Given this list of marker genes C1QTNF9, DPP4, BMP7, HSPD1, CGB3 (NCBI Gene Id 1082), VGF, NLRC4, GTF2H4, TNF, INHA, AKT2, IL22, NCF1C, AMBN, CCDC88A (coiled-coil domain containing 88A), RHEB, GFRAL, ERCC6, IFNA8, CXCL11, AGAP2, WRNIP1, SEMA4G, NRG3, SPRY2, RASAL1, PPP2R5B, SRC, TBC1D25, FGF8, MAP2K1, ARHGAP20 (Rho GTPase activating protein 20), APOA2, IL27, TBC1D13, TBC1D20, APLN, DDOST, VEGFA (vascular endothelial growth factor A), TNFSF9, CRH, LRRC32, MLST8, WNT8A, PGF, ARHGAP12, DNAJC2, RALBP1 (ralA binding protein 1), IL3, PLEKHG6, CXCL10, CCN6, THNSL2, PPBP, GHRH, EEF1A1, MMP16, LAMA5, PPP4R3A, FBLN1, INSR, EPO, SLC39A10, DEFB130A, STC2, NBL1, CTSA, AXIN1, RGS1, AZIN1, TNFSF14, ECRG4 (NCBI Gene Id 84417), DNAJA2, NPRL3, BCAS3, OGN, DMWD, TBC1D3L, PDGFRB (NCBI Gene Id 5159), LRRC52, TBC1D16, PARP1, SYDE1, CLCF1, TNFSF4, GHRL, ARHGAP24, DOCK5, SLC27A1, SIPA1L1, AGAP3, FBN2, SKP1, SUMO1, CKS2, SUZ12, ARAP3, ARHGEF19, GARNL3, CCN3, DNAJB2, FURIN, SPDYA (speedy/RINGO cell cycle regulator family member A), LTA, GNAS, KL, PDYN, GUCA1A, HRAS, LLGL2, APH1B, CXCL9, RAF1, IFNL3, TYMP, IFNG (NCBI Gene Id 3458), DAD1, MOB1A, IZUMO1, AKT1, DLL4, RANBP1, MID1IP1, ARF4, CD86, PPY, NRG1 (neuregulin 1), ARHGAP11A, NBN, GPR15LG, ARHGAP45, SGSM1, MBTPS2, SEMA6D, MT3, SH3PXD2A (NCBI Gene Id 9644), SEMA4D, PARP6, RGPD4, FGF17, DNAJB4, PAK2, APOE, CXCL5, TP53, LRPAP1, LACRT, ATP1B1, ARHGAP25, PREX1, CSF1, ARHGAP10, ADCYAP1, TNKS1BP1, CHML, GAST, CDKN1B, CCL8, CSHL1, ABI1, WNT2B, CCL5, RGS14, RGCC, GRM5, TNFSF15, CRIPTO (NCBI Gene Id 6997), DEFB110 (defensin beta 110), CCL7, TBC1D2, COPA, LGALS1, GDF6, EBAG9, SGSM3, RABGAP1, FGF5, PPP1R15A, NF1, RGS10, DBF4B, WNT16, DNAJC7, IL6 (NCBI Gene Id 3569), ANG, IL19, RACGAP1, GCN1, WNT3A, FAM3C, PRKACA, STRADA, SLX4, POMC, TBC1D2B, BCR, ATP2A3, TBCK, PARP16, UBE2N, DCP1A, PCNA, MARK2, TNFSF10, FSHB, ARHGEF12, AHSA1, ATG13, CFLAR, ASAP3, METRNL, INSL3, TNFSF18, IL1B, PYCARD, PPP2R5C, STK4, NPVF, EVI5L, AGFG1, IL32, EDA, ARHGEF1, PREX2, DAND5, NTF4, IFNA16, IL17F, PVR, ARHGAP22, TBC1D9, GAL, EIF5, NLRP3, PDZK1, NCF2, INHBB, RGS17, RBCK1, IL36RN, ARHGAP18, RABEP2, IL36A, STC1, CRIPTO3, GNAQ, ARFGAP1, HSPB2 (heat shock protein family B (small) member 2), DEFB130B, SYNGAP1, NCF1B, JAG2, WNT7B, ACTN2, MOB1B, APAF1 (apoptotic peptidase activating factor 1), MAP3K20, PDGFC, ARHGAP5, ARHGAP30, PENK, DEFB103B, ACAP2, RALGAPB, NAA15, ICOSLG, ARRB1, PLCB3, DELE1, GPRC5B, SVBP, NENF, SIPA1L3, TAOK1, COX17, BTC, PSMD14, NRTN, FNDC5, SEMA3D, RGPD3 (RANBP2 like and GRIP domain containing 3), TOR1AIP2, NAA25, PTK2B, CLU, NPPA, ANGPT2, BAG6, SEMA3C, MOB2, ARHGEF10L, OXT, DNAJA1, HSCB, IFNA6, PEX12, ADIPOQ, APOC1, IFNL2 (interferon lambda 2), TBC1D24, SRGAP2, PDGFB, CASP9, FGF3, TREM2, EDN1, GNB5, CGA, SMAP2, GALP, RGPD8, PARK7, ULBP2 (UL16 binding protein 2), RINL, NDUFA13, CA9, BNIP2, GHR (growth hormone receptor), ANK2, NDP, CD24, ARHGAP27, WNT8B, STXBP5L, TBC1D26, CCL3, ARHGAP39, FZR1, C7orf50, ASAP1, DCP1B, NKX3-1, IL5, HDGF, CRLF1, CXCL12, GNA12, NCF1, CCL18, PMCHL2, TBC1D3, ARHGEF16, CSH2, CXCL3 (NCBI Gene Id 2921), AJUBA, IL10, TNFRSF11B, CTF1 (NCBI Gene Id 1489), CLPSL2, NOXO1, INHBA, CAV1, RIN3, RASA1, TAB1, DNAJC10, PGLYRP1, ARHGAP8, PTHLH (parathyroid hormone like hormone), ADM, REG1A (NCBI Gene Id 5967), STXBP5, SEMA3B, TGFB1 (transforming growth factor beta 1, NCBI Gene Id 7040), BMP10, CMTM7, ERCC5, EED, CDK5R1, DEFB104A, IL17A, SGSM2, ARHGAP40, DOCK7, NLRP1, STAP1, ARHGAP35, DNAJC15, SEC23A, WNT10B, RLN2, WNT5A, TRH (thyrotropin releasing hormone), THBS4, AVP, ADAP1, SEMA6B, HMGA1, C5, RPLP1, UBE2L3, FGF2, PIN1, FGF20, FGF21, TG, PRKCD, NOD1, PLEK, TAOK2, JAK2, TBC1D3F, ARHGDIB, ENG, TBC1D10B (TBC1 domain family member 10B), TMEFF1 (NCBI Gene Id 8577), BCL2L13, WNT3, ARHGAP1, ARAP1 (ArfGAP with RhoGAP domain, ankyrin repeat and PH domain 1), FGF16, APELA, CCL24 (NCBI Gene Id 6369), TOM1L1, PITRM1, WNT7A, INHBE, ADAP2, TBC1D5, FGF19, PCOLCE2, LTF, MOB3B, C3, FGF13, FAM3B, ARHGEF15, RABEP1 (rabaptin, RAB GTPase binding effector protein 1), CCND1, ADA2, HSP90AB1, NXNL1, DBNL (drebrin like), ARHGAP26, NCF4, CAB39L (NCBI Gene Id 81617), RETNLB, TIPRL, TBC1D8, IL1RN, IL24, CTSG, LCK, ARHGAP19, PF4V1, GUCA1B, DEPDC1, PHACTR4, RASAL3, LRRC55, CAPRIN1, NEK9, CDK5R2, HFE, CX3CL1, CD80, ARHGEF11, NODAL, NPY, THY1, TSHB, ARHGAP33, IL23A, BMP8A, ERFE, RING1, IGF2, IAPP, CMTM5, RIN1, ARHGDIG, IL37, PPP2R5D, PRL, PMCH, HACD3, PLXNB1, FAM3D, GMFG, CCL2, LTK, RGS12, IFNK, CCL20, NAA16, MYBPC3, FRS2, RASA2, DDIT3, RAP1GAP, RPTOR, VEGFD, TBC1D3K, SERINC2, NCOR2, MAP3K13, LEFTY1, PSME1, CCL4L2, ATP1B2, IL26, PPP2R5A, DNAJC1, ACE2, HTRA1 (HtrA serine peptidase 1), PROK1, RGS9, RGS3, IFNL1, ELK1, STX4, DEFB109B, INS-IGF2, TBC1D22B, TFF1, AGAP9, CITED2, PLAA, GREM1, TCL1A, NANOS1, MGST2, IFNL4, STRIT1, NOXA1, TBC1D14, ALKAL1, INHBC, TBC1D4, WNT9A, RANGRF, ENDOU, RGPD1, NRROS, TIMELESS, FASLG, HBEGF, RASA4, IL36B, BRPF1, TBC1D3B, CMTM3, OSGIN2, SEMA3E, SFRP2 (NCBI Gene Id 6423), GMIP, VCAN, STK3, ADM2, MAPK12, CCNT1, TIMM50 (NCBI Gene Id 92609), HIF1A, ALS2CL, IFNA1, CXCL8, RGPD2, CCL11, LTB, BMP5, AGAP11, IL36G, BDNF, MET, PSME2, CD320, GMFB, TNFSF13, RAB3GAP1, ARFGAP3 (NCBI Gene Id 26286), TNFSF13B, GDF5 (NCBI Gene Id 8200), PDE8A, EPHA2, NGF, PDCD5, COLEC10, GPIHBP1, ARL1, ARHGAP31, PPP1R12B, PTPA, PSAP, ANGPTL3, IFNW1, ETAA1, PNOC, ARHGAP28, APOH, AGAP5, MTCP1, GDF9, NCKAP1L, CCNB1 (NCBI Gene Id 891), ENHO, DNAJB1, CGB2, ARHGEF6, ST20, TRMT112, JMJD6, DKK1, APP, CXCL14, GDI1, TAFA5, NANOS3, SCG2, ATP6AP1, CMTM2, IGFBP3, GPRC5D, ITGA1, IFNA4, DOCK1, NECTIN4, ALK, MACC1, CCL23, ARFGEF1, NPPC, CLTRN, DLL1, CCL17, CDKN1A, TBC1D3H, ANKRD27, DOCK4, IL9, MNAT1, RAD50, TTR, SPX, NCR3LG1, NCS1, DEFB103A, ACSL1, PPP2R5E, STK11, IFNA10, MIA2, SEMA7A, PYY3, RP2, NPRL2, AIM2, RANBP2, FNTA, HMGB2, CD40LG, DDX3X, IFNB1, GPI, ERBB3, TNFSF11, SEMA4C (semaphorin 4C), SHH, GRP, IL12A, ARHGAP15, TSC2, ALKBH1, PYY, RGS11, DOCK2, ABL1, UCN, SST, CCL27, GPR158, PRKCE, STARD13, TBC1D22A, ACAP1, DEFB133, CDNF, DEFB104B, THPO, SMDT1, CLPSL1, PTH, CDC42EP2 (NCBI Gene Id 10435), CASP1, TAFA4, SAE1, DAB2IP, FAM47E, C17orf99, RELN, SMCR8, AREG, SECTM1, DNMT3L, LTBP1, FBXW7, DPM3, EDN2, TBC1D15, FN1 (NCBI Gene Id 2335), ERRFI1, HSPA1A, NRDC, TRIB3, MOB3A, NRG2, MSMP, IFNA2, ARHGDIA, NKRF (NCBI Gene Id 55922), BGLAP, BICRA, FERMT2, GDI2, MAP3K12, ANGPT1, PARP8, CCL21, RABGAP1L, GRTP1, FAM13B, DNAJC24, FLCN, EVI5, SOS1, IL20, HLA-E, HGF, CAB39 (calcium binding protein 39), IGF1, GDF3, TAFA3 (TAFA chemokine like family member 3), CCL14, IFNE, AIMP1, TGFBR2, METRN, TBC1D12, TPX2, ANGPTL8, RGS8, CKS1B, NPFF, TOR1AIP1, PRKAG2, IL17B, GNRH2, FGF1, CHN1, SYDE2, STK39, FXYD2, IL18, IL21 (NCBI Gene Id 59067), PSENEN, ALDH1A1, ITPRIPL1, MMP15, CCND2, VIP, PTN, TBC1D30, TBC1D3E, CD48, WNK3, WDR48, IL1F10, GIT2, IGFBP5, SMAP1, MAPK8IP2, CMTM8, SEC23B, ARHGAP11B, GIT1, IL12B, MIF, PLCB1, PIK3CA (NCBI Gene Id 5290, phosphatidylinositol-4,5-bisphosphate 3-kinase catalytic subunit alpha), DEFB114, F2, FGF4 (NCBI Gene Id 2249), C9orf72, ARHGAP6, F2RL2, ARHGAP29, DNM1L (NCBI Gene Id 692222), FLT3LG, RASGRP3, CALCB, CASP3, TANK, MAL, LEFTY2, NPPB (natriuretic peptide B), NECTIN2, SEMA3F, IL31, AGT, CER1, PTEN, GM2A, ANK3, AGAP1 (NCBI Gene Id 22851), POR, IL25, SEMA3A, CMTM1, PRKRA, TGFB3, AGRP, CSF3, DBF4, PSME4, RGS18 (NCBI Gene Id 92122), HSPA8, LYN (LYN proto-oncogene, Src family tyrosine kinase), SERINC1, TGFB2, CHN2, RACK1, RICTOR, IL1A, CXCL6, XCL1, TBC1D21, AHSA2P, IQGAP1, IRGM, NEK7, TNFRSF14, IFNA5, RFC1, GCG, LEP, TBC1D3I, MADD, LGALS3, MAP2K2, MICOS10-NBL1, LRRC38 (NCBI Gene Id 126755), CCNT2 (NCBI Gene Id 905), ALS2, TNFSF12, EREG, DAXX, TEFM, SH3BP1, LIF, ACVR2B, GTF2F1, SIPA1L2, GNRH1, GDF1, OSTN, AGAP6, NHERF1, CTSH, FAM20A, GDNF, LGALS9, IFNA17, RGS5, ATP4B, NOG, AKAP9, CCL25, CALM2, INSL5, ARHGAP21, RAB3GAP2, LTC4S, USP6NL, HMGB1, LRRK2, MAP2K7, IL7, EBI3, GDF15, EDN3, FGF23, GDF2, IL13, FXN, CLEC11A, CLPS, MAP3K9, KNG1, CHGB, ELMOD2, PPP4R3B, GDF10, SAV1, MDK, GPRC5A, PCOLCE, VEGFC, ALKAL2, TBC1D1, IFNA14, LHB, STRADB, ASIP, TOPBP1, CCL19, EGFR, KITLG, CCL1, EPGN, CXCL1, INSL4, RGS2, XCL2, DNAJB6, CSF2, TBC1D17, LLGL1, RANGAP1, GRN, C1QTNF4, MYO9A, PIM1, MMP24, CSPG5, RAP1GAP2, MIA, STARD8, MANF (NCBI Gene Id 7873), JAG1, TRIM23, SDHAF4, ARHGAP9, AGAP4, CCND3, OCRL, MICA, VSIR, FLRT3, ADGRB3, TBC1D8B, EPHA7, SEMA6A, GPNMB, DPM2, WNT4, AFAP1L2, CCL22, BCL10, DLC1, CASP8AP2, ARHGAP4, ADRM1, LRCOL1, MTSS2, IL6ST, GUCA1C, PSPN, FGF18, APOA5, MYO9B, AZIN2, FGF12, DEFB4A, TBC1D3C, COQ9, RGS20, ABL2, IL15, WNT5B (Wnt family member 5B), RAMAC, CALCA, HTR2B, MLN, DEPDC5, OSGIN1, UCN3, NMB, WNT6, DUSP19, UCN2, ELMOD1, CCL26, TCL1B, TBCD, FGF14, FNTB, TAC4, NUPR1, MSTN, CCL15, TAFA1, CCL16, BAD, FGF9, IL17D, BTK, RLN3, SH3PXD2B, PRLH, MAPRE3, WNK1, GDF7, TIMP1, HDGFL3, SEMA4B, BMP1, SCT, NTF3, WNT1, CALM1, BMP8B, IGFBP7, VSTM1, GDF11, PSME3 (proteasome activator subunit 3), PTTG1, BMP6, VEGFB, GAPVD1, RETN, AGFG2, TBC1D3G, CCL28, IL11, GFER, ZP3, BEX3, BMP3, CDC20, PDGFD, LAMTOR3, BMI1, HTR2A, INSL6, B3GAT3, TBC1D3D, WDR4, OPHN1, GAS6, FYN, C1QTNF12, FGF6, CCNK, APOA4, CLPX, RGS7, TBC1D19, S100A4, ATP1B3, SEMA4F, AGAP7P, WDR41, RCVRN, TNFSF8, AMELX, CARTPT, NAMPT, NCSTN, TAGAP, ANGPT4 (NCBI Gene Id 9067), RGS6 (regulator of G protein signaling 6, NCBI Gene Id 9628), CALM3, CBX8, BMP2 (NCBI Gene Id 650), SIRT1, GUCA2A, GREM2, UTS2, GH2, PSMC3IP, GH1, GPHA2, LGMN, GPHB5, CCK, IL34, GUCA2B, GPRC5C, PIK3R1, RALGAPA1, MALT1, CLEC2B, TIFAB, NSD3, IL33, SIPA1, TBC1D9B, FGF22, ARHGAP42, MMRN2 (NCBI Gene Id 79812), MSH2, CTSC, RLN1, DNAJC19, CGB1, MOB3C, RASA4B, TBC1D10C, MLH1, LARS1, WNT9B (Wnt family member 9B), SSBP1, ROCK2, IQGAP2, CDK5, ASAP2, POLG2, IQGAP3, UTS2B, RGPD5, EFNA5, ARFGAP2, APH1A, ENTREP1, SEMA6C, CXCL16, CCL3L3, HCRT, SRGAP1, ARHGAP17, ALOX5AP, RAPGEF2, BMP4, TAFA2, WNT2, IL4, RALGAPA2, FAM13A, ARHGAP32, NRP1, GKN1, PRSS22, VCP, FHL1, CORT, CCL13, PDGFRA, DEPTOR, RGPD6, CSH1, NANOS2, PTK2, HAMP, CD33, RGS16, GIP, SEMA5B, CXCL2 (NCBI Gene Id 2920), ABR, SRGAP3, IL17C, DEPDC1B, IFNA7, COQ8A, CACNA1S, DAZAP2, VRK3, AURKA, ABHD5, ARTN, CD274, KAT2B, PRNP, EGF, CHM (CHM Rab escort protein), XRCC5, OSM, BMP15, SLURP1, CNTF, WNT11, ULBP1 (NCBI Gene Id 80329), FBN1, QRFP, WDR20, NLRP12, ARHGAP36, CXCL13, APOC2, BTRC, APOB, SEMA5A, LRRC26, TAC1, CWF19L1, ECT2, CCL4, TSLP, TOR2A, JUN, TBC1D7, RGS4, TGFA, REG3A, ARAP2, IFNA21, SCGB3A1, SEMA3G, NRG4, GUCA1ANB-GUCA1A, VPS9D1, RASA3, AMBRA1, MMP17, IGFBP2, FGF10, SEMA4A, CGB7, NOTCH1 (notch receptor 1), INCENP, FNIP1, PDPK1, ARHGAP23, ABCC9, WNT10A, RASAL2, TIAM2, PINK1, EFEMP1, NTS, ELMOD3, KRTCAP2, IL16, RIN2, PF4, SPP1, TBC1D10A, INS, PDGFA, FGF11, AMH, PPP4R3C, CD70, APOA1, SAMD15 (NCBI Gene Id 317666), ARHGAP44 (NCBI Gene Id 9912), DGKQ, ACAP3, DOCK3, FGF7, CARD8, FLRT2, IL2, CKLF, VAV3, CDC20B, here is a description of the gene set: A molecular function regulator that activates or increases the activity of its target via non-covalent binding that does not result in covalent modification to the target. studied in species Homo sapiens Human Gene Set: GOMF_MOLECULAR_FUNCTION_ACTIVATOR_ACTIVITY